Given this list of marker genes SNRNP200, CHP1, DHX38, NR2E3, ADAMTSL4, PGK1, ACTB, NHS, BBS5, DHDDS, NUBPL, TGFBI, TERT, DHX37, PDGFB, ATPAF2, IMPG1, MT-ATP8, COL11A1, RAX2, KAT6A, PEX7, OPN1LW, POGZ, CD247, TEK, SEMA4A, CHN1, ATOH7, AP4B1, AFF4, GDF6, NDUFAF8, TBC1D2B, C1QBP, AP4S1, TIMM8A, TRIM32, RP1L1, BRAF (B-Raf proto-oncogene, serine/threonine kinase), UNC119, NDUFV2, ELOVL4, AFG3L2, KRT12, NDUFS1, GM2A, ALMS1, CDC42, NMNAT1, SUFU, PIGA, PITX2, MT-ND2, SCLT1, WDR19, ELOVL1, CTNNA1, RNU4-2, OPA3, ATXN7, ITM2B, MT-ND1, IL2RB, SOBP, MT-ATP6, NYX, TMEM216, AIP, MC1R, SMARCB1, NDUFA6, IL10, LRIT3, KIF21A (NCBI Gene Id 80819), NDUFA11, LCA5, PSAP, RRAS2, CCR1, VPS11, PDE6G, RPE65, HEXB, POC1B, ARNT2, TANGO2, MTFMT, CEP290, KIAA1549, NDUFS4, UROD, MMACHC, GALC, KMT2D, ITGA2B, FKRP, AP4M1 (adaptor related protein complex 4 subunit mu 1, NCBI Gene Id 9179), CTNS, CACNA2D4, CDH23, IFT140, NDUFAF1, LARGE1, CDHR1, PIK3CA, TSEN54, C1QTNF5 (C1q and TNF related 5), RGS9, EIF4A2, CRX, SCN8A, PLG, SALL2, PCYT2, COL9A3, INPP5E, C4A, SREBF1, PRCD, H1-4, MAG, OSTM1, FAM161A, TUBA1A, MKS1, SLC45A2 (NCBI Gene Id 51151), HGSNAT, RP1, IFNGR1, IQCB1, TLCD3B (TLC domain containing 3B), ZNF408, GUCY2D, POMT2, HPS4, FREM2, PITX3, VSX1, DPP6, TSPAN12, AHI1, OCRL, EYS, GSN, PDZD8, WARS2, TOPORS, COL2A1, PXDN, PLOD1, ZFYVE26, GNAT2, XYLT1, SCN1A, BCOR, KCNV2, ATP5F1A, TMEM237, LRP5, RORA, EPRS1, B3GAT3, NDP, TRAF7, TMEM231, HCCS, CACNA1F, BEST1, BBS1, KIDINS220, MT-ND3, CHST6, NBAS, ATRX, BBS9, CCDC28B, PRPF8, P3H2, HEXA, NDUFB10, SDHB, OAT, GP1BA, CAPN5, TUB, AIRE, CEP164, DLD, CRB1, TLR4, PCARE (photoreceptor cilium actin regulator), LIM2, PPT1, PDHA1, GPR179, UFM1, SF3B2, NDUFV1, GPR143, ITGB3, TUBB2B, WDR45, ATP5F1D, UBAC2, RAC1, OFD1, RP2, ZFX, CBS, TTLL5, HMX1, PITPNM3, H4C9, TCIRG1, AP4E1, SLC1A3, ATP1A3, IMPG2, PNPT1, MED12 (mediator complex subunit 12), GATA1, TSEN15, MICU1, TWIST1, IDH3B, CNGB1, SSBP1, CFAP418, FDXR, EFEMP1, GUCA1A, SLC24A1, ZMIZ1, CRLS1, RD3 (NCBI Gene Id 343035), FRMD7, PAX2, TMEM126A, NDUFS3, ADNP, BMP4, NLRP3, MECR, SELENOI, DCT, PLA2G6, TMEM98, AP3B1, SLC38A8, NDUFA1, NDUFS8, SLC39A14 (NCBI Gene Id 23516), POLR3GL, MIEF1, SAG, DEPDC5, PIK3R2, TENM3, ARL2BP, FLVCR1, EIF2B1, MKKS, BBS12, TMEM126B, FGFR3, IMPDH1, MAK, ATIC, ABCA4, HPS5, DNAJC30, SLC7A14, XRCC4, PQBP1, MEN1, CC2D2A, PRR12, IL12A, TRPM1, OPA1, HPS3, LONP1, ASPH, NRL, MARK3, MFSD8, CA4, PRPF31, COL8A2, PANK2, PTPN22, UCHL1 (ubiquitin C-terminal hydrolase L1), TIMP3, ACO2, HLA-DRB1, ARL2, MTRR, NEK2, MERTK, TYR, ARMC9, RLBP1, TULP1, GRK1, PCYT1A, VWA8, AP1S2, PTPN2, HPS1, LZTFL1, BBS10, AKT1, TBX1, DNM1L, NPHP4, LRMDA, PDE6H, IL12A-AS1, PRPF6 (pre-mRNA processing factor 6), PDE6B, PANK4, CERKL, FZD5, MMP19, MAFB, LRPAP1, SALL4, FBXL4, FRAS1, DNMBP, BBS7, RPGRIP1, WAC, TSEN34, TFE3, IFT172, WFS1, RFT1, ATF6, MIR184, TUBB3, XYLT2, ELN, RNU12, ARL6, GNAQ, SDCCAG8, NPHP1, ABCC6, KIF11, RHO, ANKRD55, ARHGEF18, MAP3K7, IFT27, KIF1C, TRIO, ARSA (NCBI Gene Id 410), ALDH3A2, TRIM44, NF1, MED25, IL23R, LAMB2, LTBP2, SCO2, RHOA, GJB2, PIGN, OVOL2, ITPR1, CYP4V2, OCA2, DYRK1A, PHOX2A, LMBRD2, MFRP, NFIX, PRPH2, PEX6, CTNNB1, PDE6A, UFC1, IDH3A, HK1, NDUFS7, CFAP410, B4GAT1, B3GALNT2, PORCN, SEPSECS, RGR, CRYAA, NDUFB3, BTNL2, RTN4IP1, CREBBP, AGBL1, TASP1, CLEC3B, AP1G1, DRAM2, FOXL2, TUBB4B, AIPL1, TEFM, ERF, GUCA1B (NCBI Gene Id 2979), TUBA3D, PRPS1, GP1BB, USH2A, COL9A2, CNGA3, CLN3, TCF4, KCNN2, KIZ, RGS9BP, ADAMTS10, CEP250, DNA2 (DNA replication helicase/nuclease 2), NR2F1, CTC1, NDUFS6, OGT, NDUFB9, GNAS, HLA-B, HPS6, MTR, IFT43, NDUFAF5, NDE1, UROS, WDPCP, TIMMDC1, SPATA7, BLOC1S3, CLCC1, TBC1D24, ZEB1, MCAT, LAMA1, PRPF4, AHDC1, RP9, GRM6, COX7B, ATP5MK, SCAPER, SMCHD1, TOMM7, PRIMPOL, MIR204, TSEN2, IFT74, PROS1, NDUFAF2, AHR, SAMD7, FKTN (NCBI Gene Id 2218), ZNF513, CEP19, MAPKAPK3, OPN1MW, PRDX1, KIF14, NDUFS2, FZD4, GNB3, MTRFR, MLXIPL, SLC4A2, NSMCE2, PUF60, ALG3, CNGB3, ROM1, BAP1, PRPF3, SMO, RBMX, MTTP, GMPPB, CLCN7, SMARCE1, NF2, STX3, IL2RA, PI4KA (phosphatidylinositol 4-kinase alpha), ASNS, CHST3, VPS13B, SDHAF1, PDE6C, SH3BP2, NOG, WASF1 (NCBI Gene Id 8936), PRSS56, CRYBB1, IFT88, SLC4A11, ERCC4, COL4A1, PDXK, HSD17B10, KCNJ13, SDHA, ARL3, AGBL5, PROM1, LRAT, BLOC1S5, CHRDL1, ARHGEF2, FLNA, ITGA2, RDH12, RAB28, NDUFB11, STAT4, FOXC1, HDAC4, REEP6, CDC42BPB, FOXE3, DTNBP1, MYOC, ERAP1, NAA10, TUBGCP4 (tubulin gamma complex component 4), ZNF423, FBN2, CRYGC, TTC8, FOXRED1, OPN1SW, TMEM67 (transmembrane protein 67), CABP4, CD109, SARDH (sarcosine dehydrogenase), CLCN6, COL25A1, NDUFAF4, ESAM, POLG, WDR26, EBP, MEFV, ABCD1, FAS, RNASEH1, GNAT1, ASPA, KLRC4, CYP1B1, BBIP1 (BBSome interacting protein 1), BBS2, RPGR, RIMS2, RBP3, CNGA1, FGFR2, ELP4, FBN1, APC, POMGNT1, KLHL7, LYST, USP45, H4C3, RBP4, KERA (NCBI Gene Id 1256), SDHD, COL9A1, ATP5F1E, POMK (protein O-mannose kinase), GLB1, SLC24A5, NDUFAF3, BBS4, FXN, TACSTD2, P4HTM, TMEM138, YME1L1, CDH3, FSCN2, POMT1 (protein O-mannosyltransferase 1), SCYL1, GRIP1, CLRN1, POU3F4, GRHL2, RCBTB1, TNFSF11, PAX6, RIC1, here is a description of the gene set: Human Gene Set: HP_REDUCED_VISUAL_ACUITY species: Homo sapiens Reduced visual acuity